The following is a description of a gene set: The chemical reactions and pathways resulting in the breakdown of purine deoxyribonucleoside monophosphate, a compound consisting of a purine base linked to a deoxyribose sugar esterified with phosphate on the sugar. studied in species Homo sapiens Human Gene Set: GOBP_PURINE_DEOXYRIBONUCLEOSIDE_MONOPHOSPHATE_CATABOLIC_PROCESS, and this is the list of marker genes: NT5C1A, NT5C2, GDA, XDH, DNPH1, ADA, NT5C, PNP